The following is a description of a gene set: The process in which the anatomical structures of the inner ear are generated and organized. The inner ear is the structure in vertebrates that contains the organs of balance and hearing. It consists of soft hollow sensory structures (the membranous labyrinth) containing fluid (endolymph) surrounded by fluid (perilymph) and encased in a bony cavity (the bony labyrinth). It consists of two chambers, the sacculus and utriculus, from which arise the cochlea and semicircular canals respectively. studied in species Mus musculus Mouse Gene Set: GOBP_INNER_EAR_MORPHOGENESIS, and this is the list of marker genes: Fgf8, Otx2, Dvl1, Insig1, Gata3, Ripor2, Stox1, Clrn1, Sox9, Dlx5, Tbx3, Fzd6, Lhfpl5, Atoh1, Tmie, Grxcr1, Prrx2, Chrna9, Sox2, Prrx1, Ptk7, Aldh1a3, Six4, Myo7a, Cdh23, Nectin1, Ptprq, Atp2b2, Insig2, Celsr1, Slitrk6 (SLIT and NTRK-like family, member 6), Tcap, Mir96, Dvl3, Hoxa1, Fzd2, Whrn, Foxi1, Tbx18, Kcnq1, Otop1, Fgfr2, Itga8, Scrib, Gfi1, Slc44a4, Myo3b, Sobp, Pou4f3 (POU domain, class 4, transcription factor 3), Six1, Tecta, Tbx1, Dvl2, Fzd3, Pdzd7, Pax8, Cep290, Gata2, Tshr, Abr (active BCR-related gene), Rac1, Nherf1, Wnt3a, Zeb1, Grhl3, Atp8a2, Hmx2, Atp6v1b1, Pax2, Fgf10, Ephb2, Neurog1, Col2a1, Fgfr1, Dlx6, Myo6 (NCBI Gene Id 60360), Tprn, Ankrd24, Ror2, Dll1, Sparc, Otx1, Strc, Ush1c, Nr4a3, Fgf3, Chrna10, Clic5, Gli2, Bcr, Zic1, Frzb, Cthrc1, Lrig3, Myo3a, Tbx2, Fgf9, Pls1, Clrn2, Chd7, Hesx1, Hmx3, Tifab, Wdpcp, Gbx2, Ntn1, Pou3f4, Lrig1, Tfap2a, Sod1, Spry2, Foxg1, Bloc1s5, Wnt1, Mafb, Ttc39c, Kcnq4, Eya1, Col11a1, Hpn, Myo15a, Ush1g, Sec24b, Vangl2, Wnt5a, Nectin3, Grxcr2, Rest, Pcdh15, Triobp